Given this list of marker genes DNMBP (dynamin binding protein), RPS10-NUDT3, KLF17, ACTB, DIO2, PRPF38B, CDV3, BEX2, ATP6V0E2, RAP1A, EPHX3, TMEM67, HDAC2, PPP2CB, HTR1F, BOD1L2, FECH, ACVR1B, GET1-SH3BGR, KLHDC2, TBX4, ZNF671, DAB1, COL25A1, MED13, SYBU, ST6GALNAC6, AGAP2, SNCB, CSGALNACT2, ST6GALNAC5, CNTNAP4 (NCBI Gene Id 85445), TP53BP1, NR3C1, KCNG3, MED1, SRGAP2, SVIL, DDX5, NDP, ATP1B1, FGF13, TPO, EPB41L5, NUDT3, PLSCR4, ABCA12, PROX1, CPEB2, PALS1, SLC1A1, SLC8A1, MEF2A, TAFA2, RIMS2, JPH3, ARFGEF1, FAM200B, GTPBP2, SH3BGR, KCNH7, SYNE2, PNKD, ZNF638, SRSF11, NFYC, EIF5A2, here is a description of the gene set: species: Homo sapiens Human Gene Set: MIR6872_3P Genes predicted to be targets of miRBase v22 microRNA hsa-miR-6872-3p in miRDB v6.0 with MirTarget v4 prediction scores > 80 (high confidence targets). from publication Chen Y, Wang X (PMID 31504780)